Given this list of marker genes Ccna1, Chek2, Sfn, Ywhah, Cdk1, Wee1, Ccnb1, Cdc25c, Ywhae, here is a description of the gene set: This event has been computationally inferred from an event that has been demonstrated in another species.<p>The inference is based on the homology mapping from PANTHER. Briefly, reactions for which all involved PhysicalEntities (in input, output and catalyst) have a mapped orthologue/paralogue (for complexes at least 75% of components must have a mapping) are inferred to the other species. studied in species Mus musculus electronically inferred by orthology from the curated human pathway part of: G2/M DNA damage checkpoint Reactome Pathway: Chk1/Chk2(Cds1) mediated inactivation of Cyclin B:Cdk1 complex